Given this list of marker genes SLC25A37, TTYH1, MCOLN2, SLC40A1, SLC25A28 (NCBI Gene Id 81894), MCOLN1, HAMP, SLC11A1, MMGT1, SLC11A2, SLC39A14, here is a description of the gene set: Human Gene Set: GOMF_IRON_ION_TRANSMEMBRANE_TRANSPORTER_ACTIVITY Enables the transfer of iron (Fe) ions from one side of a membrane to the other. species: Homo sapiens